The following is a description of a gene set: species: Homo sapiens Human Gene Set: GOMF_PEPTIDASE_INHIBITOR_ACTIVITY Binds to and stops, prevents or reduces the activity of a peptidase, any enzyme that catalyzes the hydrolysis peptide bonds., and this is the list of marker genes: ITIH3, R3HDML, SERPINA4, HMSD, SERPINB5, CST11, WFDC13, SERPINB4, SPOCK2, SERPINE3, SERPINB12, GBP2, SERPINA7, TIMP3, CST9 (NCBI Gene Id 128822), C5, SERPINB11, APLP2, WFDC1, CST9L, LPA, SPINT1, HRG, NAIP, SERPINH1, SERPINB10 (NCBI Gene Id 5273), ITIH4, FURIN, SPINK4, SMR3A, USP14, SLCO1B7, PEBP1, PROS1, TIMP1, GPC3, SERPINA10, SERPINI2, SPINK6, COL4A3, SERPINB7 (NCBI Gene Id 8710), ITIH5, SERPINA6, A2M, AHSG, PSMF1, SERPINC1, SERPINA3, PTTG1, SERPINF2, COL6A3, SPINT4, CSTB, CST5, SERPINB13, NGF, COL28A1, SERPINE2, SLCO1B3-SLCO1B7, TFPI2, PARK7, AGT, WFDC11, CRIM1, SIMC1, CST4, ITIH6, C3P1, THBS1, SPINK13, COL7A1, SERPINB2, TIMP4, SMR3B, WFDC8, CST6, ANXA2, SERPINA5, WFDC2, SERPINA2, BIN1 (NCBI Gene Id 274), RARRES1, LTF, C3, CST1, WFDC5, SPP2, C4B, SPINT3, PI15, CST2, EPPIN, SERPINB9, SPINK14, SERPIND1, CARD17P, RENBP, SERPINB6, WFIKKN2, NLRP7, APP, CSTA, A2ML1, CSTL1, UCHL5, TIMP2, WFDC9, KNG1, SERPINA9, SERPINA1, WFDC10B, CPAMD8, SERPINI1, CD109, OPRPN, GBP5, CST3, TFPI, SERPINE1, SPINK7, CSN2, SSPOP, SPINK2, FETUB, PI3, BST2, SPINK8, WFDC12, CST8, RECK, SPINK5, XIAP, SERPING1, PI16, SPOCK3, BIRC6, ITIH2, LXN, SPINK9, BIRC5, CST9LP1, PAPLN, ANOS1, CST7, SLCO1B3, PRNP, SERPINA11, MANSC4, WFDC3, CAST (calpastatin), PCSK1N, WFIKKN1, CARD18, CRB2, SPINT2, SPINK1, ITIH1, CARD16, SLPI, WFDC10A, SERPINF1, UMODL1, SERPINB8, SERPINB1, GAPDH, SERPINB3, BIRC7, SERPINA12, LCN1, WFDC6, SNCA, AMBP, PZP, SPOCK1, SORL1, C4A